Given this list of marker genes FTL, TMPRSS6, BCS1L, FTH1, STEAP3, here is a description of the gene set: Human Gene Set: HP_DECREASED_TRANSFERRIN_SATURATION A below normal level of saturation of serum transferrin with iron. Decreased transferrin saturation species: Homo sapiens